Given this list of marker genes CBY2, TCEAL9, CYP2J2, RNASEH2C, ACAD10, APRT, PRKAG1, FBXO2, MED10, RNASEH2A, ADGRG5, TEX22, CHN1, PDLIM7, DGCR6, WDR74, LTN1, CIART, NKD1, ALKBH7, DIRAS2, RDH16, CETN2, P2RX1, FZD8, DCP2, SEC61B, PRRT2, TACSTD2, UTP6, TSHZ2, CHST15, FBXO45, BCKDHA, RAB28, MGP, HSPB8, ADGRG1, GFER, CXCL14, PFKFB3, IGHG3 (NCBI Gene Id 3502), CENATAC, POLE3, BCL11A, UCMA, NUDT16L2P, THUMPD1, POP5, MKI67, CALU, SCRIB, FOCAD, MMP24OS, SNRPA (NCBI Gene Id 6626), WDR4, SLC19A1, NELFA, CFD, TULP3, PNOC, DDX18, HGH1, PSMA1, HIC2, TCF7L1, LRRC42, RCOR1, COPS8, ETV5, TPGS1, QPCTL, IFI35, TRIM27, MEX3C, SPATA33, ZNF653, SOAT1 (sterol O-acyltransferase 1), CYTH2, ANKZF1, PNCK, DMRTC1, ZNF292, CDK2, COPS7A, CTH, SYS1, MAB21L2, TUBB, HMGN1, MRPS26, ZDHHC16, YIPF6, GPRIN1, KCNJ16, TIMM10, WBP1, CAV2, DESI1, SMC3, KLHL22, MAPKAPK3, SPEF2, EXD2, DEAF1, ARHGEF17, N4BP2L2, POR, CAPN15, PCBP4, SLC20A1, ANK1, COBL, ZNF358, SLC9A8, OTOF, NRP1, SLITRK1, NDUFB10, PRCC, PTPRE, SRSF4, PAFAH1B2, POLB, COX8A, PPP1R1A, SLC22A2, ZNF878, DYNLT4, MSC, TBP, ROPN1, TNRC18, PCYT2, SRSF2, GLOD4, RPP21, VPS51, DMPK, FZD10, CDH16, MTFP1, DAPP1, SLPI, BTBD9, CCDC65, ANKS4B, CCS, PRR32, MMUT, STRAP, FCRLA, VIPR2, BMP5, GLRX5, FIBIN, NAT8, LSM10, TBXT, GNMT, MIDEAS, STRN3, CLINT1, LEMD2, ZNF524, RASSF6, SEL1L, FAM136A, ARHGAP23, TLR1, SKIL, AGPAT5 (NCBI Gene Id 55326), HOXD10, ARF3, CLEC2L, C10orf88, here is a description of the gene set: Human Gene Set: BAKKER_FOXO3_TARGETS_DN Genes down-regulated in I/11 erythroblast cells upon expression of an activated form of FOXO3. The cooperation of stem cell factor (SCF) and erythropoietin (Epo) is required to induce renewal divisions in erythroid progenitors, whereas differentiation to mature erythrocytes requires the presence of Epo only. Epo and SCF activate common signaling pathways such as the activation of protein kinase B (PKB) and the subsequent phosphorylation and inactivation of Foxo3a. In contrast, only Epo activates Stat5. Both Foxo3a and Stat5 promote erythroid differentiation. To understand the interplay of SCF and Epo in maintaining the balance between renewal and differentiation during erythroid development, we investigated differential Foxo3a target regulation by Epo and SCF. Expression profiling revealed that a subset of Foxo3a targets was not inhibited but was activated by Epo. One of these genes was Cited2. Transcriptional control of Epo/Foxo3a-induced Cited2 was studied and compared with that of the Epo-repressed Foxo3a target Btg1. We show that in response to Epo, the allegedly growth-inhibitory factor Foxo3a associates with the allegedly growth-stimulatory factor Stat5 in the nucleus, which is required for Epo-induced Cited2 expression. In contrast, Btg1 expression is controlled by the cooperation of Foxo3a with cyclic AMP- and Jun kinase-dependent Creb family members. Thus, Foxo3a not only is an effector of PKB but also integrates distinct signals to regulate gene expression in erythropoiesis. from publication Bakker WJ, van Dijk TB, Parren-van Amelsvoort M, Kolbus A, Yamamoto K, Steinlein P, Verhaak RG, Mak TW, Beug H, Löwenberg B, von Lindern M (PMID 17353275) species: Mus musculus